The following is a description of a gene set: part of: Blood group systems biosynthesis This event has been computationally inferred from an event that has been demonstrated in another species.<p>The inference is based on the homology mapping from PANTHER. Briefly, reactions for which all involved PhysicalEntities (in input, output and catalyst) have a mapped orthologue/paralogue (for complexes at least 75% of components must have a mapping) are inferred to the other species. Reactome Pathway: ABO blood group biosynthesis electronically inferred by orthology from the curated human pathway species: Mus musculus, and this is the list of marker genes: Fut1, Fut2, Abo